Given this list of marker genes ZBTB7B, CBFB, RUNX3, LILRB4, NCKAP1L, SOCS1, RUNX1, SLC4A2, here is a description of the gene set: studied in species Homo sapiens Any process that modulates the frequency, rate, or extent of CD8-positive, alpha-beta T cell differentiation. Human Gene Set: GOBP_REGULATION_OF_CD8_POSITIVE_ALPHA_BETA_T_CELL_DIFFERENTIATION